Given this list of marker genes NLGN2, NTSR1, RIMS1, RIMS2, UNC13B, CHRNA2, ABAT (4-aminobutyrate aminotransferase), here is a description of the gene set: Any process that modulates the frequency, rate or extent of inhibitory postsynaptic potential (IPSP). IPSP is a temporary decrease in postsynaptic membrane potential due to the flow of negatively charged ions into the postsynaptic cell. The flow of ions that causes an IPSP is an inhibitory postsynaptic current (IPSC) and makes it more difficult for the neuron to fire an action potential. Human Gene Set: GOBP_MODULATION_OF_INHIBITORY_POSTSYNAPTIC_POTENTIAL species: Homo sapiens